Given this list of marker genes Acsl1, Acsl6, Thbs1, Akt1, Akt2, Irs2, Acsl5, here is a description of the gene set: Any process that modulates the rate, frequency or extent of plasma membrane long-chain fatty acid transport. Plasma membrane long-chain fatty acid transport is the directed movement of long-chain fatty acids across the plasma membrane. A long-chain fatty acid has an aliphatic tail containing 13 to 22 carbons. Mouse Gene Set: GOBP_REGULATION_OF_LONG_CHAIN_FATTY_ACID_IMPORT_ACROSS_PLASMA_MEMBRANE studied in species Mus musculus